The following is a description of a gene set: part of: CREB1 phosphorylation through NMDA receptor-mediated activation of RAS signaling Ribosomal S6 kinase (RSK) has four isoforms in humans, RPS6KA1 (RSK1), RPS6KA2 (RSK3), RPS6KA3 (RSK2) and RPS6KA6 (RSK4), and each of the isoforms have six conserved phosphorylation sites (in RPS6KA1, these are serine residues S221, S363 and S380 and threonine residues T359, T573 and T732). Phosphorylation at four of these residues appears to be critically important for the catalytic activity of RSKs: S221, S363, S380 and T573 (in RPS6KA1).<br>Phosphorylation and activation of RSKs primarily occurs at the plasma membrane, but can occur in the cytoplasm and in the nucleus. ERKs (MAPK1 and MAPK3), activated downstream of RAS signaling, phosphorylate RSKs on threonine and serine residues T359, S363 and T573 (in RPS6KA1). Phosphorylation by ERKs enables autophosphorylation of RSKs on serine residue S380 and threonine residue T732 (in RPS6KA1). Phosphorylation of RSKs by PDPK1 (PDK1) at serine residue S221 (in RPS6KA1) is necessary for the full activation of RSKs and phosphorylation of RSK substrates. RSK4 differs from other RSKs because it shows high level of constitutive phosphorylation and activity in the absence of growth factors, although it is still responsive to growth factors and ERK activity.<br>RSKs, especially RSK2, are highly expressed in brain regions with high synaptic activity. RSK2 mutations are the underlying cause of Coffin-Lowry syndrome (CLS), which is characterized by cognitive impairment and skeletal anomalies. Reactome Pathway: RSK activation species: Homo sapiens, and this is the list of marker genes: MAPK1, RPS6KA1 (NCBI Gene Id 6195), RPS6KA3, PDPK1, MAPK3, RPS6KA2, RPS6KA6 (NCBI Gene Id 27330)